The following is a description of a gene set: Wide intermamillary distance A larger than usual distance between the left and right nipple. studied in species Homo sapiens Human Gene Set: HP_WIDE_INTERMAMILLARY_DISTANCE, and this is the list of marker genes: B3GLCT, WASF1, RIT1, AHDC1, PIK3CD, TACR3, FGFR1 (NCBI Gene Id 84151), IDH1, FGF17, TP63, AMMECR1, DUSP6 (NCBI Gene Id 1848), IBA57, MAPRE2, PTPN11, BRAF, WDR11, SOS1, GPC4, TMCO1, MEG3, RTL1, GATA4, CERT1, ERMARD (NCBI Gene Id 55780), NF1, GPC3, FGF8, NRAS, TTC5, CSPP1, KIFBP, ZNF148, SPRED2, MAP2K1, TMEM94, GNRHR, CPT2, HNRNPK, RAB18, SMPD4, KRAS (KRAS proto-oncogene, GTPase), ALG14, ALG9, NHLH2, TUBB, SRY, ERCC6, RIPK4, MEGF8, NSD2, PIGN, GNB2, CDH11, ASH1L, UBE2A, SMARCA2, LAMA5, GRIP1, CHST3, MAB21L1, HS6ST1, WLS, TAC3, PACS1, KAT6A, DHCR7 (NCBI Gene Id 6589), PSAT1, SPIN4, TOGARAM1, EED, KATNB1, RAF1, EXOC2, IGF1R, TRAF7, PROKR2 (prokineticin receptor 2), KISS1R, PROK2, MRAS, EXTL3, LZTR1, PPP1CB, FREM2, NSMF, MADD, RRAS, GNPTAB (N-acetylglucosamine-1-phosphate transferase subunits alpha and beta), RASA2, TIMM50, WDR37, FRAS1 (NCBI Gene Id 84949), KNSTRN, TBL1XR1, AMER1, SOS2, ADNP, MGAT2, ARCN1, INTU, COG1, NUP188 (nucleoporin 188), KANSL1, HDAC4, COX7B, CBL, LBR, CHD7, SPRY4, RRAS2, KIAA0586, SMS, TAF4, DLK1, ASXL1, TFAP2A, CDK13 (NCBI Gene Id 8621), FGFR2, KISS1, NECTIN1, CILK1, ABCD4, GNRH1, ZC4H2, ARHGEF2